The following is a description of a gene set: part of: Glucagon signaling in metabolic regulation Reactome Pathway: PKA activation in glucagon signalling This event has been computationally inferred from an event that has been demonstrated in another species.<p>The inference is based on the homology mapping from PANTHER. Briefly, reactions for which all involved PhysicalEntities (in input, output and catalyst) have a mapped orthologue/paralogue (for complexes at least 75% of components must have a mapping) are inferred to the other species. species: Mus musculus electronically inferred by orthology from the curated human pathway, and this is the list of marker genes: Prkacb, Prkar1b (NCBI Gene Id 19085), Prkar2b, Prkaca (protein kinase, cAMP dependent, catalytic, alpha)